Given this list of marker genes FLT3, here is a description of the gene set: part of: Drug resistance of FLT3 mutants species: Homo sapiens Reactome Pathway: tamatinib-resistant FLT3 mutants Tamatinib is a type I tyrosine kinase inhibitor with activity against FLT3. This pathway describes FLT3 mutants that are resistant to inhibition by tamatinib.